Given this list of marker genes PYY3, ASIP, RXFP4, TRH, GUCA2B, PEX13, EIF2AK4, NPW, NPY5R, STAT3, LEPR, OPRK1, CPT1A, MCHR1, GAL, SGIP1, GALR3, PYY, PRLHR, CCK, PRLH, REN, P2RY1, ADM2, USP46 (NCBI Gene Id 64854), HCRTR2, NPB, MC4R, DACH1, UCN, GPR83, NPSR1, DRD1, BBS12, GLS, STRA6, TACR3, DRD2, PPY, UBR3, TACR1, GALR2, NPY2R, NTRK2, LEP, GNB3, CARTPT, TTC21B, MC3R, C1QTNF4, HCRTR1, COL6A1, TBR1, GCG, RETN, RMI1, HELT, QRFP, APLN, PMCH, IAPP, GIGYF2, FOS (NCBI Gene Id 2353), ADORA2A, INS (NCBI Gene Id 3630), AGRP, HAND2, NMUR2, OXT, BSX, DERL2, DMBX1, ADRB3, OPRD1, MMP17, MC1R (NCBI Gene Id 4157), TH, CFAP20, CNTFR, UCHL1, BBIP1, POU4F1, TMEM18, FYN, ATP8A2, HTR2C (5-hydroxytryptamine receptor 2C), GHRL, MRAP2, GPR171, NR4A3, NEGR1, NPY1R, INSL5, UCK2, NMU, GHSR (NCBI Gene Id 92434), GFRAL, TMEM63B, ACE2, NPY, NAPEPLD, SLC24A4, GDF15, BRS3, HCRT, CNTN2, UBE2Q1, EN1, here is a description of the gene set: Human Gene Set: GOBP_FEEDING_BEHAVIOR Behavior associated with the intake of food. studied in species Homo sapiens